Given this list of marker genes Slc38a7, Slc6a19, Slc36a4, Slc6a6, Slc38a9, Slc36a1, Slc6a15, Slc6a14, Slc7a10, Slc1a5, Slc38a2, Slc6a20b, Slc1a4, Slc3a2, Slc43a2, Mfsd12, Slc25a38, Slc6a9, Slc6a20a, Slc36a2, Slc38a3, Slc1a3, Slc38a6, Slc25a12, Slc7a8, Slc7a5, Sfxn1, Slc25a13, Slc6a18, Slc1a1, Slc43a1, Slc38a5, Slc1a7, Slc6a5, Slc38a4, Slc38a1, Slc36a3, Slc6a7, Slc32a1, Slc1a6, Slc1a2, Slc7a9, here is a description of the gene set: Enables the transfer of neutral L-amino acids from one side of a membrane to the other. Neutral amino acids have side chains with no charge at pH 7.3. studied in species Mus musculus Mouse Gene Set: GOMF_NEUTRAL_L_AMINO_ACID_TRANSMEMBRANE_TRANSPORTER_ACTIVITY